Given this list of marker genes Gsdmc4, Gstm3, Mthfr, Gsdma3, Hspa8, Havcr1, Anxa11, Syt7, Dpep1, Cavin2, Scarb2, Osbpl10, Syt5, Gas6, Dppa1, Plekhn1 (pleckstrin homology domain containing, family N member 1), Izumo1r, Anxa10, Gstm1, Gstm2, Syt3, Osbpl8, Timd4, Mthfsl (NCBI Gene Id 100039721), Anxa8, Anxa7, Anxa5, Ptges2, Gsr, Gsdmd, Rpe65, Cidec, Syt4, Gpr143, Mme (membrane metallo endopeptidase), Gstm7, Mthfs, Syt10, Cbs, Anxa6, Lancl1, Appl2, Gsdma, Anxa9, Timd2, Anxa13, Gstm6, Slc46a1, Mark1, Anxa1, Ftcd, Thbs1, Timd5, Mfge8, Timd6, Trem2, Syt9, Dhfr, Gnmt, Gsta2, Tyms, Dmgdh, Uros, Gap43, Anxa2, Gss, Mgst2, Asap1, Adgrb1, Cpne6, Gsdma2, Folr1, Nox4, Folr2, Anxa4, Fcho2, Marcks, Jph2, Gsdmc2, Smpd3, Cd300lf, Trim72, Rs1, Syt6, Cps1, Gstm4, Cd300a, Alb, Gsta1, Axl, Tln1, Mtr, Osbpl5, Hmgb1, Syt1, Ltc4s, Appl1, Mgst1, Gsta5, Sytl2, Cpne1, Gsta13, Slc19a1, Gramd1b (NCBI Gene Id 77787), Gsdmc, Prmt3, Mmachc, Gstm5, Scarb1, Sardh, Syt2, Gsdmc3, Ptges, Anxa3, Mmut, Fasn, here is a description of the gene set: studied in species Mus musculus Binding to a modified amino acid. Mouse Gene Set: GOMF_MODIFIED_AMINO_ACID_BINDING